The following is a description of a gene set: studied in species Mus musculus Any process that modulates the frequency, rate or extent of cell junction assembly. Mouse Gene Set: GOBP_REGULATION_OF_CELL_JUNCTION_ASSEMBLY, and this is the list of marker genes: Lrrtm1, Ube3b, Sdc4, Arf6, Farp1, Rap1a, Ppp1r9b, Oxt, Ace2, Nedd4l, Nphp4, Caskin1, Abi3, Slitrk5, Crtac1, Cux2, Crb3 (crumbs family member 3), Stau2, Myoc, Wdpcp, St8sia2, Rhoa, Gna13, Slit1, Nckipsd, Eef2k, Ntrk2, Epha3, Slk, Vps35 (VPS35 retromer complex component), Prkaca, Lrfn3, Lin7a, F11r, Ace, Cfl1, Ppm1f, Slitrk6, Efnb3, Cldn1, Robo1, Dmtn, Lrrtm4, Ptprs, Actg1, Adnp, Grid2, Thbs2, Usp9x, Ntng2, Il1rapl2 (NCBI Gene Id 60367), Ptprj, Sema4d, Crmp1, Cbln2, Amigo1, Slitrk1, Ptprd, Srgap2, Dusp3 (dual specificity phosphatase 3 (vaccinia virus phosphatase VH1-related)), Numbl, Lingo2, Rtn4, Vstm5 (V-set and transmembrane domain containing 5), Oxtr, Nrxn2, Asic2, Grin1, Nrg2 (NCBI Gene Id 381149), Elmo1, Zdhhc8, Pdzd11, Ptpra, Col16a1, Srgap3, Lin7c, Dock1 (NCBI Gene Id 71571), Snca, Cript, S1pr2, Agt, Mdga2, Dsg3 (NCBI Gene Id 13512), Vldlr, Mmp14, Nedd8, Lrrc4b (leucine rich repeat containing 4B), Carmil3, Iqsec1, Pkp2, Prickle1, Ntn1, Ntrk3, Ghrl, S100a10, Negr1, Elavl2, Gpbar1, Prkch, Il17a, Bhlhb9, Iqgap1, Slitrk3, Pum2, Cyfip2, Six1, Flot1, Wnt5a, Aplnr, Slc12a5, Arhgef15, Cntnap2, Macf1, Prkca, Adgrl3, Snai1, Amigo2, Lrfn4, Slitrk2, Rock1, Nectin1, Mark1, Cav1, Htr4, Ghsr, Dapk3, Dclk1, Efna5, Ube2v2, Apod, Adgre5, Limch1, Rps6, Vcl, Icam5, Bdnf, Lingo4 (NCBI Gene Id 320747), Src, Phldb2, Pik3r1, Xlr3b, Adgrb2, Epb41l5, Actr3, Ikbkb, Wnt3a, Poldip2, Lrtm2, Ctnnb1, Lrrn3, Nrxn1, Ptpn11 (NCBI Gene Id 72646), Ntrk1, Fermt2, Lrrtm2, Lims1, Six4, Irx3, Eif4g1, Smad3, Epha2, Snai2, Clasp2, Nlgn2, Tjp1, Dock4, Rhod (ras homolog family member D), Psd, Asic1, Adgrb3, Fgfr1, Cc2d1a, Dlg5, Rock2, Myo1c, Colq, Mdga1, Wnt7a, Coro1c, Cbln1, Sema4a, Tpbg, Ptk2, Lzts1, Podxl, App, Agrn, Abl1, Clasp1, Il1rap, Lats1, Fzd5, Lrrn1, Pten, Nectin3, L1cam, Nae1, Dock10, Cldn3, Lrp1, Tsc1, Pdlim5, Snap25, Tnf, Gpm6b, Grem1, Nlgn1, Rapgef2, Rtn4r, Rcc2, Srcin1, Rac3, Enpp2, Ephb2, Gpc4, Nrp1, Ephb3 (Eph receptor B3), Dcx, Adgrl1, Slitrk4, Neurl1a, Fzd1, Nlgn3, Abi3bp, Slit2, Flrt3, Peak1, Il1rapl1, Epha7, Thy1, Afdn, Fmn1, Wnt4, Chd4, Clstn2, Sipa1l1, Nphp1, Musk (muscle, skeletal, receptor tyrosine kinase), Numb, Gdf2, Trim47, Ldb1, Gsk3b, Ppp1r9a, Dlc1, Igsf11 (NCBI Gene Id 71858), Ptpn13, Clstn1, Rab17, Cldn5, Chrnb2, Hrg, Rhog, Camsap3, Lzts3, Lhfpl4, Il1b, Map1b, Prickle2, Rps6-ps4, Rap1b (NCBI Gene Id 72733), Lrrtm3, Dkk1, Lrtm1, Dusp22, Gja1, Tbx5, Adgrl2, Arhgap6, Dlg4 (NCBI Gene Id 13385), Sema4c, Lrfn5, Rap2a, Fam107a, Lrrc24, Lrp4, Lrfn1 (leucine rich repeat and fibronectin type III domain containing 1), Cpeb3, Rapgef1, Clstn3, Iqsec2, Amigo3, Hopx (NCBI Gene Id 74318), Adgrb1, Ptk2b, Map4k4, Flrt1, Tek, Tlr2, Ptpn1, Syndig1, Setd5, Kdr, Srpx2, Vegfa, Myh9, Nrg1, Mef2c, Arhgap33, Itgb1bp1, Sigmar1, Acvrl1, Ube2m, Cldn19, Mycbp2, Flrt2, Rac1, Ogt, Lin7b, Ephb1, Adgrl4